Given this list of marker genes IL7R, RAG2, FLG, SLC27A4, HLCS, CHD7, TGM1, ADA, RAG1, DCLRE1C, IL2RG, LIG4, RMRP, GBA1, STS, here is a description of the gene set: Desquamation of skin soon after birth studied in species Homo sapiens Human Gene Set: HP_DESQUAMATION_OF_SKIN_SOON_AFTER_BIRTH